Given this list of marker genes Hexim1, D2hgdh, Ano4, Tnfsf18, Angptl2, Wbp2, Ddx21, Hdac9, Nectin3, Plxna2, Ccdc92, Gm14434, Dnajc21, Scfd1, Gpr158, Tent5a, Ilf3, Intu, Scarb2, Cops7a, Zfp26, Prss8, Zfp27, Zfp967, Clvs1, Rarb, Zfp830, Npy4r, Il22ra1, Pde4d, Oas1g, Clec4n, Gpcpd1, Il12b, Lrrc4c, Tcf12, Ino80e, Zc3h7a, Kcna2 (NCBI Gene Id 16490), Erc1, Clpx, Zfp869, Fam91a1, Aipl1, Oxct1, Slc39a10, Cfap418, Fam184b, Zc3h12d, Plcxd2, Rock1, Bcl11b, Zfp759, Fat1, Tectb, Ctnna2, Cacna1i, Cd8a, Zswim6, Zfp966, Jrkl, Cep135, Foxk2, Cdk8, Uty, Selenop, here is a description of the gene set: from publication Chen Y, Wang X (PMID 31504780) studied in species Mus musculus Mouse Gene Set: MIR_599 Genes predicted to be targets of miRBase v22 microRNA mmu_miR_599 in miRDB v6.0 with MirTarget v4 prediction scores > 80 (high confidence targets).